The following is a description of a gene set: Mouse Gene Set: GOBP_MELANOCYTE_PROLIFERATION The multiplication or reproduction of melanocytes, resulting in the expansion of a cell population. A melanocyte is a pigment cell derived from the neural crest. It contains melanin-filled pigment granules, which give a brown to black appearance. studied in species Mus musculus, and this is the list of marker genes: Wnt5a, Fap, Or51e2, Clec12b, Tbx2